Given this list of marker genes COL4A2, LAMA5, PSEN1, CD44, MMP15, CAPN12, MMP13, CAPN15, ADAMTS9, FBN2, CAPNS2, COL4A4, CAPN11, ADAMTS4, LAMA3, KLK2, CTSK, ADAMTS18, A2M, MMP10, MMP7, MMP20, PHYKPL, MMP19, COL8A2, COL5A1, COL6A1, COL15A1, LAMB1, COL13A1, LAMB3, COL5A3, LAMC1, CAPN9, ACAN, ADAM9, TMPRSS6, ADAM8, BMP1, DCN, COL11A1, CAPN2, COL4A3, CTSB, SCUBE3, CTRB2, COL16A1 (collagen type XVI alpha 1 chain), CAPN7, PRSS1, CTRB1, COL9A1, MMP1, COL26A1, ADAM10, CTSV, MMP2, NCSTN, CAPN14, MMP8, COL9A2, COL4A6, MMP16, COL6A3, ELN, COL17A1, TLL2, COL19A1, TIMP1, ADAM15, NID1, CTSG, BCAN, SCUBE1, CAPNS1, HSPG2, COL7A1, MMP24, CAPN10, COL11A2, CAPN6, CAST, ELANE, COL12A1, ADAMTS8, CASP3, MMP17, COL6A5, CDH1, COL4A5, MMP25, FURIN, COL6A6, ADAMTS1, COL6A2, KLK7, COL1A1, MMP3, LAMC2, OPTC, FBN1, MMP12, MMP14, CAPN5, CAPN8, CTSS, TIMP2, COL9A3, MMP11, COL25A1, COL18A1, COL23A1, COL2A1, FN1, KLKB1, MMP9, COL8A1, SPOCK3, PRSS2, HTRA1, COL5A2, TPSAB1, COL4A1, COL3A1, CAPN13, ADAMTS5, COL10A1, CAPN1, BSG, ADAMTS16, FBN3, CTSD, ADAM17, COL14A1, CAPN3, CMA1 (NCBI Gene Id 1215), TLL1, CTSL, PLG, SPP1, COL1A2, here is a description of the gene set: species: Homo sapiens Reactome Pathway: Degradation of the extracellular matrix part of: Extracellular matrix organization Matrix metalloproteinases (MMPs), previously referred to as matrixins because of their role in degradation of the extracellular matrix (ECM), are zinc and calcium dependent proteases belonging to the metzincin family. They contain a characteristic zinc-binding motif HEXXHXXGXXH (Stocker & Bode 1995) and a conserved Methionine which forms a Met-turn. Humans have 24 MMP genes giving rise to 23 MMP proteins, as MMP23 is encoded by two identical genes. All MMPs contain an N-terminal secretory signal peptide and a prodomain with a conserved PRCGXPD motif that in the inactive enzyme is localized with the catalytic site, the cysteine acting as a fourth unpaired ligand for the catalytic zinc atom. Activation involves delocalization of the domain containing this cysteine by a conformational change or proteolytic cleavage, a mechanism referred to as the cysteine-switch (Van Wart & Birkedal-Hansen 1990). Most MMPs are secreted but the membrane type MT-MMPs are membrane anchored and some MMPs may act on intracellular proteins. Various domains determine substrate specificity, cell localization and activation. MMPs are regulated by transcription, cellular location (most are not activated until secreted), activating proteinases that can be other MMPs, and by metalloproteinase inhibitors such as the tissue inhibitors of metalloproteinases (TIMPs). MMPs are best known for their role in the degradation and removal of ECM molecules. In addition, cleavage of the ECM and other cell surface molecules can release ECM-bound growth factors, and a number of non-ECM proteins are substrates of MMPs. MMPs can be divided into subgroups based on domain structure and substrate specificity but it is clear that these are somewhat artificial, many MMPs belong to more than one functional group (Vise & Nagase 2003, Somerville et al. 2003).